The following is a description of a gene set: Human Gene Set: LAU_APOPTOSIS_CDKN2A_UP Genes up-regulated by UV-irradiation in cervical cancer cells after knockdown of CDKN2A. p16(INK4A) (p16) has been suggested to be an early biomarker for the detection of cervical cancer. However, its functional role in cervical cancer is not well characterized. In this study, we reported the consistent and significant upregulation of p16 in cervical cancer tissues when compared to both matched non-tumourous tissues of the same patient and normal cervical tissues from non-cancer patients. We have employed p16 small interfering RNA (siRNA) to dissect the role of p16 in cervical carcinogenesis. Although the silencing of p16 was accompanied by the upregulation of p53, p21 and RB in the p16 siRNA-transfected cells, no significant effect on cell cycle progression was observed. When the p16 siRNA-silenced cells were subjected to DNA damage stress including ultraviolet-irradiation and cisplatin treatments, a significantly higher percentage of apoptotic cells could be observed in the p16-siRNA silenced cells compared to control siRNA-treated cells. Moreover, induction of apoptosis was associated with the activation of p53 through phosphorylation, and this process, when studied by gene profiling experiments, involved both the intrinsic and extrinsic apoptotic pathways. The observation that silencing of p16 expression augments DNA damage-induced apoptosis in cervical cancer cells offers alternative strategies for anti-cancer therapies for human cervical cancer. from publication Lau WM, Ho TH, Hui KM (PMID 17369842) species: Homo sapiens, and this is the list of marker genes: MYCBP, APAF1, TP53, CARD10, BID, GMNN, BNIP2, CASP1, PAK2, PAWR, BCL2L1, BRCA1, CIZ1, RAD21, TNFRSF10B, DIABLO, PDCD6, DAP, TRAF5, BAG5, TRAF4, BCLAF1, FADD, PDCD4, PAK4, TRAF3, ACIN1, PCNA, CDKN1B, MYBL2, NDUFA13, CASP2, TP53BP2, BNIP3, TNFRSF10D, BCL2L11, CYCS, CLU, CASP8, CDKN1A, FAS, RHOB, TNFRSF12A, TNFAIP3 (TNF alpha induced protein 3), GADD45A, E2F1, CFLAR, MYC, TNFSF9, PDCD11 (NCBI Gene Id 22984), BCL10, NFKBIA, PDCD6IP, PTRH2, SIAH1